Given this list of marker genes STX12, RARA, YWHAB, NSMF, SLC10A2, IL17RA, CH25H, BACH1, ARHGEF28, HLA-G, CELF4, CDKN2A, TRIM11, HOXA1, FSTL1, DERL2, SNAI2, APLF, LSS, HDHD5, TWSG1, FHOD3, ZNF532, B4GALT3, ZG16 (zymogen granule protein 16), PLSCR1, ARMC10, PRX, TYR, HPX, KCNH1 (potassium voltage-gated channel subfamily H member 1), EXT2, TIPARP (NCBI Gene Id 25976), SLC12A7, HLA-DMA, IRF3, SLC2A2, UTP14A, TBC1D24, GADD45G (growth arrest and DNA damage inducible gamma), GADD45A, SOCS3, HS3ST3A1, KRT7, CHGA, MRPL57, AQP8, TAX1BP1, RPGR, KCND3, CD8A, NFIA, APOC1, SPATA13, IPO8, BARX1, MIDN, COMMD1, ADAM28, CBX7, SFRP4, NID2, HTR2C, RSPO2, FCGR2B, IL1RN, TMEM40, ACTN2, NELFCD, LYSMD2, MAP3K8, HOXB13, POPDC3, GNAI1, TRAK1, COPB1, IFIT1B, MAP3K1, SELENBP1, ITSN1, ZNHIT1, TMEM176A, FAM3B, SIT1, GLCE, ENTREP3, C19orf12, RBM22, PAX5, COL1A2, CDK2AP1, PLAT, GRIN2B, MT1E, PIK3CD, RNF38, SPMAP2, SOWAHC, ATP1B1, VAMP2, LHX9, FGF6, ZFAND5, ALAS1, NUDT3, DTD1, MBD6, CCT6B, CLEC3B, GNG10, SMARCA4, PPIE, INPP5D, GNA13, MCFD2, SYTL4, HAPLN1, CTSK, RAG1 (recombination activating 1), LPL, TNXB, BCKDHB, ORC4, MYD88, SIRT3, HAL, APLN, SFRP1, PSMD5, RBM10, MYO1B, CADPS, CBFA2T3, SREBF1, H1-8, CD3G, ABCA2, LY86, ECI1, ZNF282, TGFB1I1, NFIB, COL13A1, GHRHR, MAPK6, C19orf53, PITPNM1, GALNT1, SAA1, RBMS1, DCLRE1A (NCBI Gene Id 9937), SLC30A4, CDKN2D, AGTR2, STARD3, TTC3, B3GNT2, NCR1, CPNE3, ECHS1, SLC25A4, USF1, SCAF8, EHF, ALOX15B, PAK2, WNT1, CISH, SF3B5, GUCA2B, PIM2, CYP3A4 (cytochrome P450 family 3 subfamily A member 4), PGLYRP1, TIMM10B, EPYC, CDH5, COL11A2, APCS, ALDH7A1, LY6E, CXCL9, DMBT1, GJA1, SF3A1, ERRFI1, AGFG1, SEPTIN1, DNAJA3, COMMD5, APOF, PLXND1, SALL3 (spalt like transcription factor 3), PROCR, RPL30, NEK2, SULT4A1, NPY1R, FCER2, PYGO2, CEBPD, here is a description of the gene set: from publication Yosef N, Shalek AK, Gaublomme JT, Jin H, Lee Y, Awasthi A, Wu C, Karwacz K, Xiao S, Jorgolli M, Gennert D, Satija R, Shakya A, Lu DY, Trombetta JJ, Pillai MR, Ratcliffe PJ, Coleman ML, Bix M, Tantin D, Park H, Kuchroo VK, Regev A (PMID 23467089) Genes down-regulated in CD4 T helper cells (52h): Th0 versus TGFB1 and IL6. species: Homo sapiens Despite their enormous importance, the molecular circuits that control the differentiation of Th17 cells remain largely unknown. Recent studies have reconstructed regulatory networks in mammalian cells, but have focused on short-term responses and relied on perturbation approaches that cannot be applied to primary T cells. Here, we develop a systematic strategy – combining transcriptional profiling at high temporal resolution, novel computational algorithms, and innovative nanowire-based tools for performing gene perturbations in primary T cells – to derive and experimentally validate a temporal model of the dynamic regulatory network that controls Th17 differentiation. The network is arranged into two self-reinforcing and mutually antagonistic modules that either suppress or promote Th17 differentiation. The two modules contain 12 novel regulators with no previous implication in Th17 differentiation, which may be essential to maintain the appropriate balance of Th17 and other CD4+ T cell subsets. Overall, our study identifies and validates 39 regulatory factors that are embedded within a comprehensive temporal network and identifies novel drug targets and organizational principles for the differentiation of Th17 cells. Human Gene Set: GSE43955_TH0_VS_TGFB_IL6_TH17_ACT_CD4_TCELL_52H_DN